Given this list of marker genes Bet1l, Msx3, Nkx6-2, Rpl21-ps13, Or13s1-ps1, Glrx3, Ppp2r2d, Gm18258, Scgb1c1, Mir7062, Echs1, Cfap46, Syce1, Gm16201, Or6b13, Or13a20, Or13a25, Tcerg1l, Gm2044, Or13w1-ps1, Cyp2e1, Jakmip3, Gm4974, Or13a18, Dpysl4, Or13a21, Gm4459, Pwwp2b, Zfp941, Paox, Ric8a, Or12j3, Gm5650, Mapk1ip1, Zfp511, Utf1, Or12m1-ps1, Mir6401, Or13a17, Adam8, Fuom, Tubgcp2, Gm17841, Or6ae1, Or13x1-ps1, Gm30808, Or13a19, Or13a23-ps1, Mir202, Gm9358, Gm6376, Or13a22, Scart2, Lrrc27, Gm6314, Adgra1, Cimap1a, Spef1l, Scart1, Or12j4, Gm7380, Or13o1-ps1, Or6f2, C330022C24Rik, Or13a27, Or12j5, Sprn, Or13a24, Bnip3, Caly, Mtg1, Prap1, 9430038I01Rik, Kndc1, Or12j2, Urah, Gm32486, Or13a28 (NCBI Gene Id 258966), Inpp5a, Mir7686, Or2j6, 4930543N07Rik, Stk32c, Or13a26, Gm29799, here is a description of the gene set: Mouse Gene Set: chr7F4 species: Mus musculus